The following is a description of a gene set: Human Gene Set: MIR607 studied in species Homo sapiens from publication Chen Y, Wang X (PMID 31504780) Genes predicted to be targets of miRBase v22 microRNA hsa-miR-607 in miRDB v6.0 with MirTarget v4 prediction scores > 80 (high confidence targets)., and this is the list of marker genes: KIAA0825, TYW5, RAB8B, THSD7A (NCBI Gene Id 23249), KCNT2, IKZF3, EDIL3, SFT2D1, GIPC2, MARF1, IGIP, PRLR (prolactin receptor), IFI16, COMMD2, FEM1C, PGAP1, LONRF2, FOXJ3, SUPT3H, UXS1, SLC7A11, PSIP1, ZBTB1, ENPP1, SLC44A1, SMAD5, API5, PRKCB, PI15, COA1, LHX9, PPP2R2A, FBXO9 (NCBI Gene Id 26268), STXBP5, IGSF3, STARD4, ZFYVE16, LRRC8B, MON2, GOLGA6L4, INTS13, LMO7, ETNK1, ZNF717, GJA1, CRIPT, TADA2B, BCLAF3, SCCPDH, RECK, BTLA, AK7, PTBP2, PELI1, CCNT2, C1GALT1, FNDC3B, TOMM6, TECRL, ZDHHC15, SSMEM1, PTPN11, ALG10B, STK26, TRIP11, SGPP1, AP1G1, UBTD2, KDM3B, ANK2, PDLIM5, SLITRK5, CACNB4, HNRNPR (NCBI Gene Id 10236), TPRX1, RIF1, TMED7 (NCBI Gene Id 51014), TMTC2, DCBLD2, RUNX2, MTSS1, ARFGEF3 (ARFGEF family member 3), PPP4R2, ZMAT3, SMIM13, SLC16A1, INTS6, USP46, BMPR2, ZNF454, IRX2, DBT, TSFM, SWAP70, ARRDC3, KLHL5, KIN, ARHGAP5, GRIN2A, SAT1, RIMS2, ANKRD22, CFTR, CSPG5, CASP1, KIF14, AGPS, PSG1, GABRG1, LSM8, REPS2, ZBTB4, FLT1 (fms related receptor tyrosine kinase 1), RAPGEF6, SLC4A10, MEIOB, SERTAD2, LATS2, COBLL1, GNE, KLF10, DISC1, ZHX1 (NCBI Gene Id 11244), CCNY, MIA3 (NCBI Gene Id 440718), SLC35F3 (NCBI Gene Id 148641), HSPA4L, IRF2BP2, FAM13A, HDAC9, ZPBP, PROSER2, ABHD10, ITGB8, KCNC2, ITM2B, NSUN6, GOLGA6L10 (golgin A6 family like 10), CLOCK, GABRA2, GPHN, NLRC3, GPNMB, CADM2, SP3, PDE7A (NCBI Gene Id 5150), PDS5B, BLOC1S6, AASDH, NFIA, TRAK1, TENM1, PSMD11, ZBTB33, E2F6, NAPB (NSF attachment protein beta), ADAM22, CCNB1, ZNF112, LRCH2, TRPC5, DCAF8L1, SAR1B, CAND1, CYP4V2, ATP10D (ATPase phospholipid transporting 10D (putative)), DLGAP1, ATXN7, GNAQ, MTMR10, MTMR2, VGLL3, RNF4, GK5 (glycerol kinase 5), GJB2, GABRA4, ZNF695, CNOT8, JRKL, TMF1, ZFP91, PGM2L1, CDK17, PCDH15, WDHD1, PRMT3, SLC25A24, LRP2BP, TMEM245, CCAR1, PRTG, NDUFA5, ILDR2, ESRRG, SIRT1, RBM27, VAMP4, PRKAA2, TBC1D9, MSX1, MYO10, AP1AR, ZNF711, NEGR1, ENPP2, EIF1AD (eukaryotic translation initiation factor 1A domain containing), PFKFB2, REEP1 (receptor accessory protein 1), INO80D, DOP1B, GSPT1, KLHL2, CBFB, RCHY1, ARHGEF12, PREX2, ZNF708, TDP2, PRSS23, TP53BP2, IRAK3 (NCBI Gene Id 11213), THAP9, LRP11, MTDH, ARL6IP5, PIK3CG (NCBI Gene Id 5294), NLK, GABPA, RBFOX1, HOXA3, PRRC2C, CDK13, ABHD13, SMAD2, SLC12A2, MAP3K20, C1orf146, PPIL6 (peptidylprolyl isomerase like 6), BZW1, CEACAM8, ZDHHC21, RNF180 (ring finger protein 180), DNAH10, FAM168B, MKRN1, NAALADL2, ARHGAP26, NDUFAF5, CDK12 (cyclin dependent kinase 12), DCUN1D5, C2orf68, ARIH1, SLC30A7, TAGAP, CEP63, PTPDC1, SYPL2, TMEM35A, RBBP9, JAG1, CASK, BMP2K (BMP2 inducible kinase), MCM8, POGLUT1, SYPL1, MOB1B, GLRB, KLHL28, JCHAIN, RBM18, DKK2, ZNF407, ZNF608, VCF1, C9orf72, FAXC, BACH1, MEDAG, OPRM1 (opioid receptor mu 1), CSNK1A1, DHX15, MGAT4A, CEACAM5, TM9SF1, KDELR2, NFAT5, PRKAA1, NR1D2, TBL1XR1, MAP3K7, CLVS2, ZCCHC2 (zinc finger CCHC-type containing 2), RC3H1, FAT3, PTPN12, MXD1, GCN1, MTMR9, HMGCS1, TFEC, USP31, NDUFS1, HOXD3, STOX2, CXADR, IRF2BPL, ATXN3, CDH6, LYPLA1, GPR37, SLIT2, TARDBP, RPS6KB1, SLITRK2, AGAP11, SPIRE1, BICC1, KLF12, KLHL24, UBP1, PARP8, PCBP1, COL5A1, FBXO30, EEF1AKMT2, TULP4 (TUB like protein 4), PEX13, CWC22, GGCX, FECH, SNTG1, FAM120B, USP53, IGF2BP3, DNAJC3, MAN1A2, MPP4, G6PC1, WASHC4, PSG5, PCMTD1, PARP11, GPAM, THAP2, UGGT1, ZBTB8A, GADD45A, HK2, NECAP1, TECTB, AGAP5, TMEM70, ITPRID2, RUFY2, CCDC141, DEPDC7, CNTN4, CCNT1, BIVM, SLK, KCTD12, PDIK1L, ZMYND15, ZC3H14, S100PBP, ACVR2B, STRBP, GTF2A1, GRIP1, CSRNP3, MRPS10, CXCL8, USP1, HOOK3 (hook microtubule tethering protein 3), PTCD2, PLEKHF2 (pleckstrin homology and FYVE domain containing 2), PDCD6IP, ACTR2, GYG1, LHCGR, WDR17, EIF1AX, IL5RA, STXBP5L, ST8SIA4, SLC38A4, DENND4A, SPTA1, KL, ZNF518A, NAV2, PLXDC2, TRPC5OS, SRSF4, SP4, PNISR, PSMD14, TMEM43, MAN2A1 (NCBI Gene Id 4124), ATF7IP, TMX1, NEK7, LNPK, BMP3, TMEM170B, CDK6, DOK5, CASQ2, SPAG16, UNC5C, RNF144B, SDK2, EFR3A, NUFIP2, TLK2, SHISA9, MIB1, COG5, RAP2C, ATRX, TRIM44, ARL5B, DTL, GPR26, PURA, CDC14A, CNTLN, NRG4, MBNL3, ROBO1, FOXO1, AFDN, NRBF2, GEM, CRYZL1, ZDHHC14, TTC14, ZNF250, MATCAP2, SERPINB4, BRWD3, TSHZ3, DYNC1I1, MARK1, AKAIN1, CEP135, HOXD13, BCAT1, RAB12, KIF21A, MLXIP, USP38, IKZF5, TAF5L, ZBTB44, CCDC71L, SHROOM4, PPM1L, XKR9, GFPT1, STK39, IFNG, NUDT11, RNF128, ZNF546, FGL1, PITPNC1, TEX30, TDG, MSANTD4, USP33, MDGA2, UGT2A3, ZNF318, PRRG4 (proline rich and Gla domain 4), ARID1B, ELK4, MDFIC, DCX, PURG, TWSG1, PKNOX1, STX12, RAG1 (NCBI Gene Id 5896), UBXN2B, PDZD2, FOXF1, MAP3K2, GOLGA6L9, SELENOT, SLC2A2, MBNL1 (NCBI Gene Id 9850), CCNYL1, RORA, PCNP, NPY1R, ATP11C, ERBIN, TMEM106B, TFB2M, PURB, MARCHF8, MTMR12, PAXIP1, CERS3, STXBP4, CLEC4D, MED12L, USP9Y, FAM124A, SCN9A, ZNF12, TBC1D1 (TBC1 domain family member 1), FSD1L, CPSF4, WIPF1, UBASH3B, RICTOR, STK17B, SRSF1, ARL13B, CBLL1, ACKR3, RPRD1A, AFF4, ARL5A, PAPOLG, ZNF471, CEP41, MSRB3, EXTL2, RBM47, MBTPS2, SPRY2, SLFN11, SOCS4, C8orf34, ZFR, HLCS, CHIC1, QKI, PPP6R3, RASA2, NRK, SH3BGRL, RAB11FIP2 (RAB11 family interacting protein 2), XPOT, YAE1, PCDH7, PRDM5, TMEM33, C2orf88, CDIN1, C1orf56, GBP2, NKIRAS1, TMED4, BANK1, MYO5A, SERPINB3, CXCL14, GMNC, MOSPD1, CCDC126, BCL7B (BAF chromatin remodeling complex subunit BCL7B), BOD1L2, ARFGAP3, EIF3A, SCARA3, RESF1, RP2, PIK3CA, POLR2M, PGRMC2, SEH1L, SLC1A3, LPGAT1, ATG4C, FBLN5, PALS2, TTC33, GNG2, PEAK1, MFAP3, CPEB1, UBE4B, STRN, ELAVL2, TRA2A (NCBI Gene Id 29896, transformer 2 alpha homolog), C18orf54, ASF1A (anti-silencing function 1A histone chaperone), CSMD2, ERI2, MDM1, FGF12, C10orf90, FGF7, TBC1D12, B3GNT9, GCNT1 (glucosaminyl (N-acetyl) transferase 1), SUCO, JADE3, CD302, SLC16A7, HDAC8, ARX, JMY, EOGT, SUZ12, DENND1B, SMC5, SPATA13, ONECUT2, CAPRIN1, PLCB1, HIVEP2, CDKL1, GDA, PPP3R1, GRM5, LRCH1, MLLT3, NAA16, PREPL, SUCLG2, LARP4B, SYT14, PSG2, PRR32, TAFA1, NIBAN1, FAM13B, LZIC, MCTS1, C2orf72 (NCBI Gene Id 257407), CNKSR2, FEM1B, LY75-CD302, GALP, ESR1, AKIRIN2, SLC45A4, CREB1, DCUN1D1, PTBP3, SPN, CTBS, NNT, AZIN1, KANSL1L, USF3, SLC66A1LP, SALL3, TRAPPC13, BDP1, SCAI, ADAMTSL1, GUCY1A2, PRKG1, FYTTD1, TSHZ2, ZBTB41, ITGB1, BTBD3, NUDT21, DCUN1D3, NET1, IMPA1, CREBZF, PHTF2, STEAP2, TSPAN12 (tetraspanin 12), NEK1, PAFAH1B2, FN1, FXR1, ZNF737, AZI2, SERINC1, SPATS2L, DNAJC12 (DnaJ heat shock protein family (Hsp40) member C12), AGAP4, ELAVL4, EDNRA, NIPAL1, GCLM, ARF6, YTHDC2, FGL2, NRG3, AKAP11, ABHD5, TLL1, DUS4L, PLSCR4, IKBIP, GPR88, ACAP2, BACE2, RSBN1, FIGN, DDX5, LANCL2, PDK1, PRP4K, TACC1, ZBTB20, TMEM59 (transmembrane protein 59), AHR, GPM6A (glycoprotein M6A), CCZ1B, ARHGAP12, SNX19, SP8, ITGAV, SINHCAF, TRPC6, DDX3Y, CILK1, TFDP2, CIP2A, LHFPL6, LRRC58, TFAP2E, OAT, FZD3, VPS26A, NAA30, TEX10, AEBP2, MDM4, ERP44, HERPUD2, OTOGL, TTC39B (tetratricopeptide repeat domain 39B), CAMK4, PAX6, MED13, TMEM74, ZNF449, MBTD1, SPOPL, ZXDC, UBE2B, SLC35A3, REEP3, KLHL9, WASF1, MCFD2, PLD5, KLHL31, AGAP6, MMP16, MAB21L1, IQGAP2, TM7SF3, TET1, PGAP2, FMR1, KIAA0408, GSKIP (NCBI Gene Id 51527), LACTB, PRPF38B, ATP2B1, GTPBP10, WWC3, GMPR2, EFCAB5, ITM2A, FZD6, TMEFF2, NINL, MAMLD1, LCORL, ZCRB1, TSPAN13, MKRN3, CNTN1, ZEB2, CREB5, FOXN2, YIPF6, GTF2I, SRP68, THAP6 (THAP domain containing 6), SPOCK3, TMEM26, PGR, C2orf49, STT3A, UBE2D1, TRIM71, PCSK1, VRK1, PRKACB, FRS2, PLSCR1, PMPCB, RAB6B, TENT4B, AQP9, GAREM1, PHACTR3, SLC25A46, RFTN2, PABIR2, PSG3, CTSS, GSPT2, TOX, ST8SIA2, USH2A, UBE2Q1, ERC2, UBE3C, SRGAP1, TCF12, RNF149, SLC41A1, ABCA9, KLF7, ACVR2A, OSTM1 (NCBI Gene Id 28962), KLF6, ANKRD44, PYHIN1, MACROD2, C21orf91, PAH, PTPRB, TRPC1, C17orf58, HECW1, CD83, PBX1, CSN2, TM9SF3, YTHDF3, NFKBIZ, RBMS3, SPAG9, PRKACA, SPDYE5 (NCBI Gene Id 442590), PDHB, ADAMTS5, CLEC2D, PDE8B, DAZ3, CLPX, CBLB, DLD, DCUN1D4, SAMD8, APPL1, KCNQ3, SPTY2D1, IGF1, NSL1, SATB2, ITGB6, PPP1R3B, NADK2, DCLK1, FSD2, PCDH19, GTF2H3, FAM133A, PTPN4, POGK, SSBP2, CTNND2, CFAP90, TLCD4, NIPA1, PHC3, ABHD18, DENND5B, PTGER2 (prostaglandin E receptor 2), SKP2, CYP2U1, PKD2, LIN7A, TMEM14A, TNRC6B, DAZ4, SEMA5A, FAM13C, SKAP2, ERCC6L2, ARHGAP32, HIVEP3, ASB8, MAGI3, ZNF770, DOCK5, GPATCH11, RNF7, PIP4P2, KCNMA1, CTSE, ZKSCAN8, KLF15, FAM169A, TRPA1, ZNF706, DOK6, MMP12 (NCBI Gene Id 4321), PHIP, CNST, TMEM260, SELENOI, ERMN, MITF, ACTR3, TIPARP, CORO1C, RFX3, RBP2, SH3BGRL2, ABCB10, SANBR, AGFG1, MAN1A1, LBH, TENT5A, MFSD14B, SPRED1, CHEK1, BICRAL, SV2C, CHM, FUT9, DPY19L3, RCAN2, SYNPO2, ZFC3H1, KCNQ5, DGKH, MAP1B, DNAJB9, ETV1, HAPLN1, CFAP161, SRSF2, HSPB3, USP54, MAP7D3, CD93 (NCBI Gene Id 54591), DNM3, PIAS2, MYLK3, HTR1F, CUL3 (cullin 3), APOOL, IDI1, BLTP1, BIRC6, KALRN, TRDN, ALS2, ENPP5, LYSMD3, CREM, RAN, SPCS3, DDX52 (NCBI Gene Id 113523), HYCC1, TSNAX, CPSF6, NCKAP1, PLEKHA1, HOXD8 (NCBI Gene Id 56182), DIP2B, MAMDC2, NMBR, SP1, ANKRD28, SOX2, SCML1, UBLCP1, FBXW2